The following is a description of a gene set: Human Gene Set: REACTOME_BRANCHED_CHAIN_AMINO_ACID_CATABOLISM Branched-chain amino acid catabolism species: Homo sapiens, and this is the list of marker genes: DBT, DLD, ACAD8, ACADSB, BCKDHB, SLC25A44, ECHS1, BCKDK, BCAT2, HSD17B10, PPM1K, MCCC1, IVD, MCCC2, ACAT1, HIBCH, BCKDHA, ALDH6A1, AUH, HIBADH, BCAT1